The following is a description of a gene set: studied in species Homo sapiens from publication Wei G, Wei L, Zhu J, Zang C, Hu-Li J, Yao Z, Cui K, Kanno Y, Roh TY, Watford WT, Schones DE, Peng W, Sun HW, Paul WE, O'Shea JJ, Zhao K (PMID 19144320) Human Gene Set: GSE14308_TH17_VS_INDUCED_TREG_UP Multipotential naïve CD4+ T cells differentiate into distinct lineages including T helper 1 (Th1), Th2, Th17, and inducible T regulatory (iTreg) cells. The remarkable diversity of CD4+ T cells begs the question whether the observed changes reflect terminal differentiation with heritable epigenetic modifications or plasticity in T cell responses. We generated genome-wide histone H3 lysine 4 (H3K4) and lysine 27 (H3K27) trimethylation maps in naïve, Th1, Th2, Th17, iTreg, and natural (n)Treg cells. We found that although modifications of signature cytokine genes (Ifng, Il4, and Il17) partially conform to the expectation of lineage commitment, critical transcription factors such as Tbx21 exhibit a broad spectrum of epigenetic states, consistent with our demonstration of T-bet and IFN-gamma induction in nTreg cells. Our data suggest an epigenetic mechanism underlying the specificity and plasticity of effector and regulatory T cells and also provide a framework for understanding complexity of CD4+ T helper cell differentiation. Genes up-regulated in comparison of Th17 cells versus induced regulatory T cell (Treg)., and this is the list of marker genes: BIK, KXD1, ABCG2, CNR2, DCAF11, TCF12, DNAH8, SLC4A7, ERLEC1, PIGZ, OSBPL8, SMPD2, SMC4, DCTN3, GPX7, SACS, ITCH, RPL17, AMN1, CFAP68, PSENEN, FYTTD1, YME1L1, PPP1R12C, ZNF354C, TOR1B, MAN1A1, ZCCHC24, SPATA6, CRYBG1, VTI1B, UBXN4, RASGRP4, TMEM45A, SLC43A2, MAGI2, PLCXD1, EPS8L1, RNF4, JKAMP, GYG1, SP3, RNF38, TRIP12, MEX3B, VPS26B, BLVRB, INO80D, ST3GAL1, HSP90AA1, RNASE4, PRKDC, GGNBP2, SLC6A13, MKRN1, RPL31, KDM5A, LRP12, ATOX1, MTA3, FOXO3, ABRACL, TMEM18, ZBTB33, TIPRL, GUCY1A1, TLR1, APLN, STX7, HOOK2, ATG4C, BTF3, H1-0, ACTG2, EXOC5, MRPL52, VIPAS39, YIPF5, PHF6, INPP1, VAMP1, TTBK2, SRI, CRTC3, GPM6B, NEB, FEZ2, UBXN2A, TPST2, ADAM9, STXBP4, ZC2HC1A, TMIGD1, RASSF2, VPS26C, PPP1R18, HABP4, ALKBH4, RNF19A, C6orf62, ATP11C, CENPE, DQX1, ROMO1, GPR37, TSPYL4, PLEKHF1, B3GNT3, RCBTB2, ARL6IP1, WASHC4, LRIF1, SIK3, INPP5K, SPEF2, TBX6, STAG1, SUPT20H (SPT20 homolog, SAGA complex component), P2RY10, P2RX4, GADD45A (NCBI Gene Id 1647), IK, STYX, CNP, AMMECR1L, ATG16L2, ING3, ATRX, NT5DC1, GSPT2, MED20, BRMS1, OLA1, POLR3GL, NFAT5, THY1, RAP1B, USF3, OAZ2, DNAJA1, UBAC2, AK3, PAIP2, SNAPC1, DNAJB4, EDEM3, XYLT2 (NCBI Gene Id 64132), YOD1, RAB33A, ORC4, HYCC2, FXYD7, EHMT2, GUCA1A (guanylate cyclase activator 1A), APC, INHBA, MCAM, TBX20, ECHDC2, PPP2R5E, SPPL2A, KDM5B, ARB2A, SNAI3, HELB, ENTPD5, NCOR1 (NCBI Gene Id 9611), CCDC82, NFKBIE, MYCBP2, ZNF329, ADAMTSL5, IQSEC1, FAM13B, RICTOR, ATRAID, DDRGK1, NDUFA13, B4GALNT1, HOXA7, P2RY2, PKM, CCDC39, FMO5, TACC1, TMOD3, TSPAN4, ZFP36L1, PARP8, IGFBP4, RHOBTB2, ESF1, DHRS7, ETAA1, ATP2B1, SSBP1, METTL5, ANAPC11, SRSF10, CCDC92